Given this list of marker genes RNF170, SMAP2, NR3C1, TNFSF15, SPINT1, POU2AF1, RPS3, DRICH1, HOXC5, SDK1, SMUG1, ESRRG, RBFA, FNDC5, C11orf91, MLX, KCNH7, TUT7, PTGFRN, C12orf56, EFHC2, MTA3 (NCBI Gene Id 731342), PATE4, NDRG3, SPRY3, HNRNPU, MLEC, LHFPL4, LZTFL1, IL10 (interleukin 10), NMNAT2, XYLB, GP6, TRIM72, TWIST2, RANBP1, EPHA6, STYX, STAC, ISL2, CASR, POU2F2, CBFA2T3, TMEM121B, SMIM43, LRATD2, CRTC1, PEG10, TOM1L2, ARF3, TNC, RORA, MTCL2, C9orf152, POU4F2, TSPAN6, AAK1, ZKSCAN8, NSD1 (NCBI Gene Id 6797), DUSP8, HMOX2, TNRC6B, FER1L6, SFMBT2 (Scm like with four mbt domains 2), RIMS3, SCN7A, LSM12, DVL3, ZNF671, ZC4H2, ARHGAP31, MAP7D1, NT5E, KLRC3, GFPT2, TMA7, KRTAP4-4, NMBR, PCYT1B, ATP1A3, NAT2, GNAQ, GNG5, NPTXR, C1QTNF1, ATRX, SCUBE3, SLC5A9, KLF9, TENT4B, SUMO3, PHF21A, HDGFL3 (NCBI Gene Id 50810), SPA17, ATP1B2, DOCK5, TXNDC8, USB1, MAP1B, ZNF24, COPS7B, ELFN1, LILRA1, ATRAID, BASP1, CACNG3, RPS6KA3, GCH1, PEX19, ACTR1A, CIMIP6, CASP14, BTBD9, SF3B1, here is a description of the gene set: Genes predicted to be targets of miRBase v22 microRNA hsa-miR-6758-5p in miRDB v6.0 with MirTarget v4 prediction scores > 80 (high confidence targets). from publication Chen Y, Wang X (PMID 31504780) studied in species Homo sapiens Human Gene Set: MIR6758_5P